Given this list of marker genes BBIP1, HTR7P1 (5-hydroxytryptamine receptor 7 pseudogene 1), TBC1D1, CHI3L2, PLCB1, CD163, CHUK, ZNF292, COL3A1, EIF1B, BTBD3, USP13, GNGT1, RASA1, NEFH, MEGF9, SPAST, RPS10, BRWD1, RWDD2A (RWD domain containing 2A), MAPK9, PLEKHM1 (pleckstrin homology and RUN domain containing M1), LRRC32, SCN2B, CBLN1, CERS6, SEC23IP, ST3GAL2, ZNF160, MLEC, MAPK6, DAG1, HOMER1, UHRF2, RAB22A, VPS41, GFRA1, PER2, ISG15 (NCBI Gene Id 9636), LYPD1, ADH6, AMIGO2, CTSC, RBM15B, LAIR2, LOX, BRPF1, USP24, PTP4A1, CYLD, LYST, ST7, ZNF140, ELOA, AKAP9, TOX3, FDX1 (ferredoxin 1), CSN1S1, NAT8, PNO1, SLC39A14, TRAF3IP1 (NCBI Gene Id 26146), KIF20B, ELMO1, DNAJC6, PTPN12, MSL3, WDR45, RPL23AP53, ANXA9, DHH, PHKG2, CHKB, DBP, LGALS3, LTA, SPTSSA, ARF3, CUL2 (cullin 2), IGHV3OR16-13, PACRG, BBS9, TESK2, TBL3, CCR2, NME1, UBXN2B, FUBP3, LRRN3, TTC22, KLHL18, RNH1, TWIST1, GTF2E1, AP1G1, POLR2F (RNA polymerase II, I and III subunit F), TNFRSF9, COL15A1, SPRED2, CFL1, NELL2, FEZ2, GPR6, ANKRD12, IGHM, RAMP1, GOSR2, SLC5A6, PDAP1, SLC35D1, MBD1, TRPC1, RSU1, SATB2, CPSF1, MTCL1, CRY1, LOXL1, PPM1F, EVI2B, PROM1, LY6H, CCNC, SELENOW, TRIM9, YJU2B, VPS13A, CDC6, DLGAP5, CELA2B, WSCD2, PEX3 (NCBI Gene Id 8504), GCDH, ZNF354A, PLCH2, KDELR2, PEX1, ITPK1, MED13L, SF3A3, AGTR2, TRAT1, CXCL10, MYO5A, CCNT1, XCL2, ZBTB33, MTMR6 (NCBI Gene Id 9107), GNAI1, DELE1, NR4A1, TRAK2, GPNMB, SERPINB3, TMPRSS15 (transmembrane serine protease 15), TSPYL1, MNDA, PPIA, TCF3, RPE65, LTB, MED13, AGTR1, SEMA3D, G3BP1, PSMD13, SLC16A1, SGCG, TLR1, KDM1A, POT1, TBL1X, KCNJ13, RUVBL1, APOA4, CRTAM, HMG20B, HSPA4 (heat shock protein family A (Hsp70) member 4), ZNF529, PIAS4, S1PR1, KIAA1549L, ADORA2B, HSP90AA1, SGCA, ANO3, MNT, DMC1, MYH15, CSNK2B, CS, CDH8, MRPL49, CDC25A (cell division cycle 25A), GYG1, AHR, CCR4, DUSP10, POM121L1P, here is a description of the gene set: Systemic lupus erythematosous (SLE) is an autoimmune disease with an important clinical and biological heterogeneity. B lymphocytes appear central to the development of SLE which is characterized by the production of a large variety of autoantibodies and hypergammaglobulinemia. In mice, immature B cells from spontaneous lupus prone animals are able to produce autoantibodies when transferred into immunodeficient mice, strongly suggesting the existence of intrinsic B cell defects during lupus. In order to approach these defects in humans, we compared the peripheral B cell transcriptomes of quiescent lupus patients to normal B cell transcriptomes. species: Homo sapiens Human Gene Set: GSE30153_LUPUS_VS_HEALTHY_DONOR_BCELL_UP Genes up-regulated in B lymphocytes: systemic lupus erythematosous (SLE) versus healthy. from publication Garaud JC, Schickel JN, Blaison G, Knapp AM, Dembele D, Ruer-Laventie J, Korganow AS, Martin T, Soulas-Sprauel P, Pasquali JL (PMID 21886837)